Given this list of marker genes PHF19, TAF1, MORC3, CBX8, CDYL2, CBX2, ZMYND11, KMT2E, HDGFL2, H1-2, PWWP2A, ZCWPW2, CDY1, CBX5, ATRX, FGF2, CHD8, DPF2 (NCBI Gene Id 5977), SUZ12, RRP8, CHD1 (chromodomain helicase DNA binding protein 1), CDY1B, PHF13, UHRF2, PHF1, TDRD3, MTF2, YEATS4, PHF8, TAF7 (TATA-box binding protein associated factor 7), ZMYND8, TAF3, PHF2, MLLT3, BRD3, SPIN1, ING4, ING5 (NCBI Gene Id 84289), SGF29, MPHOSPH8, BRD2, SPIN2A, RAG2 (recombination activating 2), LRWD1, ZCWPW1, FMR1, CHD5 (chromodomain helicase DNA binding protein 5), SPIN2B, ING3, UHRF1, SPIN3, DPPA3, ING2, BRD7, WDR5, CXXC1, MORC4, MSH6 (NCBI Gene Id 2956), SPIN4, ING1, PYGO1, here is a description of the gene set: Human Gene Set: GOMF_HISTONE_H3_READER_ACTIVITY studied in species Homo sapiens A histone reader that specifically binds either to an unmodified histone H3 or a form modified by a post-translational modification on a specific residue. The most common PTMs on histones are methylation, acetylation and phosphorylation.